The following is a description of a gene set: Human Gene Set: GSE12198_CTRL_VS_HIGH_IL2_STIM_NK_CELL_UP Transcriptional profiling of NKAES-derived NK cells after 7 days of culture compared to primary human NK cells and NK cells stimulated by low or high dose IL2 after 7 days of culture. Genes up-regulated in NK cells: primary versus stimulated by high dose of IL2. from publication Fujisaki H, Kakuda H, Shimasaki N, Imai C, Ma J, Lockey T, Eldridge P, Leung WH, Campana D (PMID 19383914) studied in species Homo sapiens, and this is the list of marker genes: TTC4, ENTPD6, APOBEC1, SLC5A5, PDE9A, ZNF48, DGKZ, SLC41A1, SLC66A2, COX18, PDLIM4, BVES, ZNF565, HSD17B13, NELFCD, GPR65, PIP5KL1, NANP, TMEM140, GRAMD1A, SMOC2, GPM6B, MAPK6, KIRREL1 (kirre like nephrin family adhesion molecule 1), APOD, ST6GALNAC2, ZFYVE27, WNT6, RNF34, ZNF202, FOXN1, TRIM41, PCGF2, SLC44A2, GAD2, FECH, TMEM132A, PLCB2, NECTIN1, TSPAN5, PAWR, JAG2, GRAMD2B, SETD4, F10, GPR35, CTNNB1, NCOA1, TCL1A, C11orf91, HAS1, NPNT, MSR1, STIMATE, ASB8, TENT5C, ZNF841, ATOH1, STX12, CPN1, VAMP1, ZMIZ2, VPREB3, ATF1, KRT6A, SLC6A4, USP5, CORT, ACP1, MAP4K4, UGP2, IRX6, CFAP141, CASQ2, STXBP4, AGER, MAS1, ZFYVE26, B4GALT3, CYBRD1, WRNIP1, SHCBP1, MAP3K14, FCGR1A, ABCA3, CBX5, PCLO, TRIM37, HDDC2, ADNP2, IGHMBP2, THBS4, COL5A3, CTC1, DNAJB8 (NCBI Gene Id 165721), SP6, KIF17, RNMT, NFAM1, WNT9B, SELP, CHODL, PGS1, ARFRP1, RNF220, FLOT2, RORA, DUSP16, CEACAM21, LARP6, RND3, FLII, NKAIN4, DDR1 (discoidin domain receptor tyrosine kinase 1), SRMS, PLAC8, RSPH9, KRT34, CERT1, IKZF2, HSD3B1, JAK3, BCAS2, GTF2I, KLHL1, DUSP6, MAP2K4, CRAT, PLCG1, WNT5B, SLC52A3, KRI1, PRSS35, HTRA2, CPEB1, NAP1L1, ABCB1, AQP5, SGTB, UBE2L3, RTP4, COL6A1, LRRC3B, BIRC3, STYXL1 (serine/threonine/tyrosine interacting like 1), FOXN4, DNAH8, AMPH, OXSR1, BCS1L, ITPK1, LMX1A, KLF12, MOGAT2, GFOD2, PCSK5, CLBA1, CCL4, POU2F2, COPRS, PEX2, DNMT3B, CLDN10, CSTPP1, EMID1, POC5, OAZ1, BEX2, DAZ2, RAD52 (RAD52 homolog, DNA repair protein), MFAP5, IL17RA, PCP2, ANKEF1 (ankyrin repeat and EF-hand domain containing 1), AXIN1, SAYSD1, CEP68, PRIM1, NPL, BCL3, PLEKHN1, CKMT1B, GATM, THRAP3, CCR2, TPTE, PLA2G4F, AMMECR1L, CWH43, SOCS3, EIF3E, HLCS, MYORG, SLC4A8, KHDRBS1, DCTN1, NDEL1, PCSK6, RHOV